Given this list of marker genes SORT1, BDNF, RAPGEF1, CD2AP, NTRK1, SHOC2, MAGI2, NTF4, RAP1A, NGF, KIDINS220 (kinase D interacting substrate 220), RAPGEF2, NTF3, CORO1A, here is a description of the gene set: The series of molecular signals initiated by nerve growth factor (NGF) binding to its receptor on the surface of a target cell, and ending with the regulation of a downstream cellular process, e.g. transcription. Human Gene Set: GOBP_NERVE_GROWTH_FACTOR_SIGNALING_PATHWAY species: Homo sapiens